Given this list of marker genes SLC6A4, DMRTA1, SEMG1, APP, THRB, P2RY1, MAPK8IP2, THRA, FUOM (NCBI Gene Id 282969), PI3, EDDM3A, DRD1, MTNR1A, HDAC2, TACR1, PPP1R9B, PPP1R1B, NCOA1, ABAT, DDO, TH, EDNRB, ADA, DRD5, AVP, NHLH2, AVPR1A, ACVR2A, OXT, KLK14, TAC1, HEXB, SERPINE2, UBE2Q1, P2RX1, here is a description of the gene set: Human Gene Set: GOBP_MATING_BEHAVIOR studied in species Homo sapiens The behavioral interactions between organisms for the purpose of mating, or sexual reproduction resulting in the formation of zygotes.